Given this list of marker genes CCNA2, GTF2H2, UBE2I, POLH, RFC2, RAD51D, GPS1, NEIL1, SMARCA5, MAD2L2, RCHY1, INO80D, PRPF19, H2BC12L, RFC4, RFC3, EYA4, POLR2A, H3-4, DCLRE1B, POLR2F, CETN2, REV3L, SIRT6, H2AC18, POLN, RAD52, PPP4R2, RIF1, SPIDR, NBN, ABRAXAS1, PPP4C, PIAS3, RAD23A, H2AX, MSH6, XAB2, EYA2, FANCM, CDK7, ADPRS, MNAT1, KDM4B (NCBI Gene Id 23030), POLR2L, POLR2J, RBX1, SUMO3, TRIM25, RAD51AP1, H2BC12, XRCC5, UBE2L6, BLM, ERCC5, RFC1, POLR2G, CCNH, RUVBL1, RPA3, INO80C, PPP5C, RAD23B, COPS7B, RNF4, UBE2V2, ISG15, H2BC15, CHEK1, PCNA, RNF8, CUL4B, CUL4A, UVSSA, POLD3, H2BC9, PMS2, CCNA1, SUMO1, TERF1, ERCC2, FANCC, BRCA2, UFD1, H2AJ, CENPX, TDG, H4C1, H2AB1, RNF111, NEIL3, USP1, WDR48, PARP1, H2BC5, PIAS4, FANCE, COPS3, H2BC3, H2BC11, USP10, RTEL1, SLX4, H2AC14, RFC5, CHEK2, XRCC2, XRCC3, ELL, BRCC3, INO80, DDB2, PARP2, H2BC17, ATRIP, EYA3, KAT5, NEIL2, XRCC6, PAXIP1, ERCC6, SLX1A, APBB1, POLL, POLB, RAD51, RAD51B, KDM4A, TOP3A, DCLRE1C, MSH3, USP7, MBD4, BABAM2, TDP1, ALKBH3, NTHL1, DCLRE1A, APEX1, POLQ, MGMT, COPS8, POLD1, FANCI, PIAS1, DTL, RBBP8, POLE4, TERF2IP, EME1, ALKBH5, GTF2H4, MCRS1, H2AC6, H2BC14, MUS81 (MUS81 structure-specific endonuclease subunit), PPIE, EME2, FAN1, POLE3, UBXN1, H2AZ2, BRCA1, ASCC2, TERF2, UBC, H2AC7, UBE2B, XRCC1, UBA7, TFPT, TCEA1, UBE2T (ubiquitin conjugating enzyme E2 T), ZNF830, FANCB, REV1, POLR2K, COPS6, POLR2H, BARD1, ATR, MDC1, SUMO2, FANCF, ERCC8, KPNA2, H2BC4, ISY1, MPG, XPC, H2BC1 (H2B clustered histone 1), POLD2, TIMELESS, SPRTN, COPS7A, UBB, FTO, SMUG1 (NCBI Gene Id 23583), HUS1, UNG, ACTL6A, NFRKB, RAD18, COPS5, MAPK8, POLE (NCBI Gene Id 80252), H2BC26, POLR2E, NSD2, CENPS, EXO1, RHNO1, ERCC3, PNKP, FEN1, FANCA, UBE2N, ATM, AQR (aquarius intron-binding spliceosomal factor), SEM1, COPS4, INO80B, ASCC3, RAD9B, VCP, INO80E, GTF2H5, XPA, RAD51C, CDK2, RAD50, DNA2, UIMC1, RMI2, FANCD2 (NCBI Gene Id 2177), PCLAF, FAAP24, LIG1, RAD9A, TDP2, PALB2, PARG, GEN1, POLD4, YY1, TINF2, POLR2I, COPS2, H2AC20, TP53, ACTR5, FANCL, H2AC4, FAAP100, BAZ1B (bromodomain adjacent to zinc finger domain 1B), EYA1, POLM, H2BC21, USP43, POLR2C, ACTR8, RNF168, FAAP20, ACTB, POLR2B, FANCG, LIG3, ERCC1, GTF2H3, TOPBP1, ALKBH2, TIPIN, BRIP1, GTF2H1, XRCC4, CHD1L, ABL1, NPLOC4, MLH1, POLI, POLE2, ERCC4, HERC2, BABAM1, POLK, UBA52, ASCC1, USP45, OGG1, CLSPN, POLR2D, ACD, POT1, RAD1, H2BC13, LIG4, MUTYH, FIRRM, RMI1, RPA2, FIGNL1, WRN, RPS27A, MSH2, BAP1, RAD17, MRE11, PRKDC, DDB1, RPA1, NHEJ1, TP53BP1, here is a description of the gene set: species: Homo sapiens DNA repair is a phenomenal multi-enzyme, multi-pathway system required to ensure the integrity of the cellular genome. Living organisms are constantly exposed to harmful metabolic by-products, environmental chemicals and radiation that damage their DNA, thus corrupting genetic information. In addition, normal cellular pH and temperature create conditions that are hostile to the integrity of DNA and its nucleotide components. DNA damage can also arise as a consequence of spontaneous errors during DNA replication. The DNA repair machinery continuously scans the genome and maintains genome integrity by removing or mending any detected damage.<p>Depending on the type of DNA damage and the cell cycle status, the DNA repair machinery utilizes several different pathways to restore the genome to its original state. When the damage and circumstances are such that the DNA cannot be repaired with absolute fidelity, the DNA repair machinery attempts to minimize the harm and patch the insulted genome well enough to ensure cell viability.<p>Accumulation of DNA alterations that are the result of cumulative DNA damage and utilization of "last resort" low fidelity DNA repair mechanisms is associated with cellular senescence, aging, and cancer. In addition, germline mutations in DNA repair genes are the underlying cause of many familial cancer syndromes, such as Fanconi anemia, xeroderma pigmentosum, Nijmegen breakage syndrome and Lynch syndrome, to name a few.<p> When the level of DNA damage exceeds the capacity of the DNA repair machinery, apoptotic cell death ensues. Actively dividing cells have a very limited time available for DNA repair and are therefore particularly sensitive to DNA damaging agents. This is the main rationale for using DNA damaging chemotherapeutic drugs to kill rapidly replicating cancer cells.<p>There are seven main pathways employed in human DNA repair: DNA damage bypass, DNA damage reversal, base excision repair, nucleotide excision repair, mismatch repair, repair of double strand breaks and repair of interstrand crosslinks (Fanconi anemia pathway). DNA repair pathways are intimately associated with other cellular processes such as DNA replication, DNA recombination, cell cycle checkpoint arrest and apoptosis.<p>The DNA damage bypass pathway does not remove the damage, but instead allows translesion DNA synthesis (TLS) using a damaged template strand. Translesion synthesis allows cells to complete DNA replication, postponing the repair until cell division is finished. DNA polymerases that participate in translesion synthesis are error-prone, frequently introducing base substitutions and/or small insertions and deletions.<p>The DNA damage reversal pathway acts on a very narrow spectrum of damaging base modifications to remove modifying groups and restore DNA bases to their original state.<p>The base excision repair (BER) pathway involves a number of DNA glycosylases that cleave a vast array of damaged bases from the DNA sugar-phosphate backbone. DNA glycosylases produce a DNA strand with an abasic site. The abasic site is processed by DNA endonucleases, DNA polymerases and DNA ligases, the choice of which depends on the cell cycle stage, the identity of the participating DNA glycosylase and the presence of any additional damage. Base excision repair yields error-free DNA molecules.<p>Mismatch repair (MMR) proteins recognize mismatched base pairs or small insertion or deletion loops during DNA replication and correct erroneous base pairing by excising mismatched nucleotides exclusively from the nascent DNA strand, leaving the template strand intact.<p>Nucleotide excision repair pathway is involved in removal of bulky lesions that cause distortion of the DNA double helix. NER proteins excise the oligonucleotide that contains the lesion from the affected DNA strand, which is followed by gap-filling DNA synthesis and ligation of the repaired DNA molecule. <p>Double strand breaks (DSBs) in the DNA can be repaired via a highly accurate homologous recombination repair (HRR) pathway, or through error-prone nonhomologous end joining (NHEJ), single strand annealing (SSA) and microhomology-mediated end joining (MMEJ) pathways. DSBs can be directly generated by some DNA damaging agents, such as X-rays and reactive oxygen species (ROS). DSBs can also be intermediates of the Fanconi anemia pathway.<p>Interstrand crosslinking (ICL) agents damage the DNA by introducing covalent bonds between two DNA strands, which disables progression of the replication fork. The Fanconi anemia proteins repair the ICLs by unhooking them from one DNA strand. TLS enables the replication fork to bypass the unhooked ICL, resulting in two replicated DNA molecules, one of which contains a DSB and triggers double strand break repair, while the sister DNA molecule contains a bulky unhooked ICL, which is removed through NER.<p>Single strand breaks (SSBs) in the DNA, generated either by DNA damaging agents or as intermediates of DNA repair pathways such as BER, are converted into DSBs if the repair is not complete prior to DNA replication. Simultaneous inhibition of DSB repair and BER through cancer mutations and anti-cancer drugs, respectively, is synthetic lethal in at least some cancer settings, and is a promising new therapeutic strategy.<p>For reviews of DNA repair pathways, please refer to Lindahl and Wood 1999 and Curtin 2012.<br> Reactome Pathway: DNA Repair